Given this list of marker genes STAG2 (NCBI Gene Id 10735), FGFR2, DDR2, POMT1, EDNRA, ORC6, CHN1, NIPBL, FKRP, WBP4, GRIP1, SOST, TP63 (tumor protein p63), POLR1B, POMT2, ERBB3, GSC, COL2A1, TBC1D24, GLI3, BRD4, SALL4 (NCBI Gene Id 57167), TAF6, HDAC8, FAT4, EFTUD2, KIF15, VPS37A, SNRPB, NOTCH3, COL7A1, KMT2D, IPO8, SLC26A2, CDC45, SMC3, SIX5, MRTFA, POR, FREM2, HGD, RPL26, MAF, TSR2, NSD2, PLCB4, FGFRL1, DCHS1, TCOF1, SMC1A, LETM1, GNAI3, EYA1, CDC6, RAD21, HMX1, TBX15, ORC4, TWIST2, FANCI, CDT1, MED12, EGFR, POLR1C (NCBI Gene Id 9533), ANAPC7, LARGE1, FRAS1, ATP6V1B2, EDN1, FKTN, TSHZ1, PAX1, SLC12A2, B3GLCT, HOXA2, MAFB, PORCN, RPS26, GMNN, POLR1D, SMCHD1, CTBP1, GPRASP2, ORC1, CPLX1, SP7, ADAM17, AKT1, SIX1, CHRNG, RPL11, RPS28, SF3B4, COG1, SF3B2, here is a description of the gene set: Abnormal auditory canal morphology Human Gene Set: HP_ABNORMAL_AUDITORY_CANAL_MORPHOLOGY studied in species Homo sapiens Any structural abnormality of the external acoustic tube (also known as the auditory canal).